The following is a description of a gene set: from publication Sakai Y, Honda M, Fujinaga H, Tatsumi I, Mizukoshi E, Nakamoto Y, Kaneko S (PMID 19074895) Hepatocellular carcinoma (HCC) is frequently associated with infiltrating mononuclear inflammatory cells. We performed laser capture microdissection of HCC-infiltrating and noncancerous liver-infiltrating mononuclear inflammatory cells in patients with chronic hepatitis C (CH-C) and examined gene expression profiles. HCC-infiltrating mononuclear inflammatory cells had an expression profile distinct from noncancerous liver-infiltrating mononuclear inflammatory cells; they differed with regard to genes involved in biological processes, such as antigen presentation, ubiquitin-proteasomal proteolysis, and responses to hypoxia and oxidative stress. Immunohistochemical analysis and gene expression databases suggested that the up-regulated genes involved macrophages and Th1 and Th2 CD4 cells. We next examined the gene expression profile of peripheral blood mononuclear cells (PBMC) obtained from CH-C patients with or without HCC. The expression profiles of PBMCs from patients with HCC differed significantly from those of patients without HCC (P < 0.0005). Many of the up-regulated genes in HCC-infiltrating mononuclear inflammatory cells were also differentially expressed by PBMCs of HCC patients. Analysis of the commonly up-regulated or down-regulated genes in HCC-infiltrating mononuclear inflammatory cells and PBMCs of HCC patients showed networks of nucleophosmin, SMAD3, and proliferating cell nuclear antigen that are involved with redox status, the cell cycle, and the proteasome system, along with immunologic genes, suggesting regulation of anticancer immunity. Thus, exploring the gene expression profile of PBMCs may be a surrogate approach for the assessment of local HCC-infiltrating mononuclear inflammatory cells. Selected genes down-regulated in inflammatory monocytes infiltrating hepatocellular carcinoma (HCC). Human Gene Set: SAKAI_TUMOR_INFILTRATING_MONOCYTES_DN studied in species Homo sapiens, and this is the list of marker genes: NCOA4, CPSF6, CDKL1, HNRNPA2B1, UBE2E3 (ubiquitin conjugating enzyme E2 E3), GLRX2, RAD51C, PRDX2, AK6, DDX20, MED7, PRP4K, FKBP3, LSM6, PRKAR1A (NCBI Gene Id 5573), SRSF1, XPO1, CD1D, CD163, PPP2R2C, CD86, CDK7, PSMA5, PCNA, GEMIN4, KAT2A, PRDX6, SNRPB2, FCGR1A, CDC27, RAN, UBE2R2 (ubiquitin conjugating enzyme E2 R2), TBP, WRN (WRN RecQ like helicase), SCAND1, PRDX1, TAF6L, PSMB5, COPS5, IFI30, TXN, IFI6, STX5 (NCBI Gene Id 6811), SNRPF, NCOR1, PPP6C, HSPA5, ERO1A, KDR, PPIA, CDC73, PTGES3, RBM8A, EPB41, NUP107, CD63, A2MP1, PPIC, GTF2I, CCNG2, H1-6, GTF2H3, CDC42, CCT8, TBPL1, PPIB, CLEC4M, MGST2, CDKN3, SUB1, TOP2A, CSTF2, SEC63 (NCBI Gene Id 55399), PRDX3, ARIH1, DNAJA1, CCNC, CCT4, DCT, NEK1, MACF1